Given this list of marker genes Hif1an, Maea, Sptlc2, Usp25, Tmem150c, Cgas, Rslcan18, Pcdh8, Naip6, Zfp446, Nid1, Dph6, Lhx6, Tcaim, 2510009E07Rik, Nipal1, Ythdc2, Chst11, Zrsr2, Creb3l1, Peak1, Rnpc3, Chn1, Fgf11, Cnksr2 (NCBI Gene Id 245684), Tns1, Tlx1, Nck2, Tenm2, Adtrp, Sytl5 (NCBI Gene Id 278231), Slc8a3, Rara, Tafa3, Hspg2, Kcnip3 (Kv channel interacting protein 3, calsenilin), Scn2a, Dhfr, Wars2, Mical2, Pdxk, Katnal1, Thada, Slc24a2, Slc37a1, Ccdc115, Sh3bp5, Fblim1, Zfp37, Nmrk2, Zmat4, Nfat5, AW554918, Tmem236, Tcp11l1, Wdr46, Ulk1, Ift57, Arhgap26, Sri, Nat8l, Man1c1, Map7d1, Fzd7, Xk, Cap2, Itgam, Slc6a17, Mrps25, Cask, Sh3rf3, Ppfia2 (protein tyrosine phosphatase, receptor type, f polypeptide (PTPRF), interacting protein (liprin), alpha 2), Tcte1, Camk1d, Tnfrsf11a, Plcb1, Terf2ip (telomeric repeat binding factor 2, interacting protein), Nr4a2, Rnf150, Treml2, Wipf3, Bicd1, Mylk4, Tor3a, Gas2l1, Hivep3, Mmp12, Foxl1, Dcx, Eogt, Aldh5a1, Scn3b, Cd19, Mcu, Prc1, Gna13, Gm4925, Gjc3, Cldn34c1, Micu2, Atg7, Mex3a, Gid8, Baalc (brain and acute leukemia, cytoplasmic), Slc48a1, Gabrb3, Dnaaf5, Bmpr2, Lrrc61, Fgf23, Tktl2, Steap2, Ado, 9330159F19Rik, Slc17a5, Pclo, Plxdc2, C1ql3, Zfp655, Zfp712, Ptchd1, Sh2d2a, Sox7, Frk, Rfx7, Adarb2, Tmem151b, Slc2a12, B4galt6, Sv2b, Flnb, Gcnt4, Unc93a, Pou2f2, Camta1, Hrh1, Rims2, Gm12886, Sipa1l1, Prkn, Tmem26, Ddr1, Vezt, Zkscan1, Dcaf17, Zdhhc21, Ogdh, Trp53i11, Astn1, Oacyl, Mapk8, Acsl4, Acot4, Pcdhgb4, Cntn2, Stxbp5, Dcaf1, Irag1, Stk10, S2bpcox16, Fig4, Znrf3, Mnt, Cd300ld, Shroom3, Enpp1, Sin3a, Cox16, Katnip, Kcna7, Apba1, Trmt2b, Zfp46, Depdc5, Ugt2b34, Ptpre, Gm5141, Alox8, Dtx3l, B3galt6, Ap1ar, Mtmr12, Rfx3, Enox2, Gas2l3, Amotl1, Ttll1, Hnrnpa0, Tigd5, Zfp663, Wiz, Sdr42e1, Rbm34, Cmklr1 (chemerin chemokine-like receptor 1), Kmt5a, Ttc39b, Elavl3, Tnrc6c, Neurod2, Tet2, Kif1a, Cd2ap, Mllt3 (myeloid/lymphoid or mixed-lineage leukemia; translocated to, 3), Micall1, Gnat1, Phf1, Pcdhga11, Mbnl3, Sbk3, Osr1, Psd2, Foxk1 (forkhead box K1), Evx2, Ssr1, Liph, St8sia1, Zfp276, Zfp936, Rhou, Abce1, Acot2, Rnf44, Vipr2, Syt15, Arih1, Pcdhga1, Nedd4l (NCBI Gene Id 83814), Opcml, Il18r1, Tsn, Apbb2, Ackr4, Efna5, Gnal, Cbln3, Zfp39, Tubb4a, Cacna2d4, Dio2, Asah2, Myo5a, Trim65, Asxl2, Calcoco1, Tafa1, Acvr2b (NCBI Gene Id 75114), Fbrs, Baz2b, Pappa2, L1cam, Ddx19b, Coq8a, Ms4a5, Tmco1, Bcor, Atp7a, 1700025G04Rik, Slc35a3, Lyrm9, Meak7, Grid1, Nab2, Pld5, Myorg, Zfp91, Ipcef1, Esf1, Med14, Dse, Eda2r (ectodysplasin A2 receptor), Ncam1, Chd7, Tmem18, Zfp68, Zfp764, Elovl6, Pappa, Maf, Lipe, Sim1, Vps33a, Bgn, Alpl, Trim60, Pik3r5, Itga9, Napepld, 2810021J22Rik, Srpx2, Zfp1008, St8sia3, Lclat1, Ms4a4c, Net1, Mlxip, Capn6, Unc13b, Gcnt1, Alkbh7, Map3k7, Chic1, Bst1 (NCBI Gene Id 269647), Glra2, Gfpt1, Cds2, Olig2, Ccdc85a, Sowahb, Eif4e, Muc13, Slc39a14, Elfn1, Cdc42ep4, Pakap, Tamalin, Elfn2, Ubxn2b, Rusf1, Atp11a, Podn, Actr10, Igf2r, Kcnmb1, Pign, Cplx3, Insyn2a, Rgs4 (regulator of G-protein signaling 4), Bltp3b, Pitpnc1, Cdc6, Smo, Havcr2, Zfp976, Fndc7, Tnfrsf13c, Nfya, Pgm5 (phosphoglucomutase 5), Ccdc125, Zyg11b, Mta3, Ly6g6c, Alg12, Acss1, Bard1, Nalf1, Gabrb2 (NCBI Gene Id 78533), Gm14391, Ifnlr1, Tmem132b, Cyfip1, Mrgpre, Yipf6, Iars1, 1700028K03Rik, Ppp1r16b, Kif3a, Kmt5b, Ubxn2a, Ajap1 (adherens junction associated protein 1), Gm38666, Thsd4, Prex2, Cacna1c, Mbtd1, Nufip2, Ncoa2, Zbtb7b, Vamp5, Klhl23 (kelch-like 23), Kras, Mettl27, Tnpo3, Arhgef17, Kank2, Uncx, Pfkfb2, Ddo, Vti1a, Ccdc3, Pcdhgc3, Kirrel3, Pcdhga6, Sox5 (NCBI Gene Id 319649), Ubtf, Sv2a, Cplx2, C5ar2, Thsd7a, Grik3, Coq5, Zfp799 (NCBI Gene Id 240064), Klf12, Fam186b, Prss42, Srgap3 (SLIT-ROBO Rho GTPase activating protein 3), Trim12c, Chrnb4, Desi2, Nqo2, D630023F18Rik, Plp1, Zfp691, Kif5a, Dlgap4, Cyb5b, Krt222, Ewsr1, Lgals12, Pcdhgb2, Mapkbp1, Fech, Orai2, Mmp28, Setd7, Prpf4, Cdh6, Arhgdib, Fam149b, Mfap3l, Pgrmc1, Nsun3, Cd84, Siah2, Angpt2, Zfp113, Acsm2, Pck2, Slc5a8, Nkx2-9, Prkcb, Wnt4, Ttc12, Zfp612, Cer1, Fgf12 (NCBI Gene Id 320320), Ehd4, Zfand5, Zfp329, Asb13, Cyp2j12, Itga3, Xylb (NCBI Gene Id 235676), Xpr1, Tacc1, Porcn, Prrc2b, Pde10a, Cyth3, Zfp575, Spock2, Sox1, Pate9, Tmem200a, Casp6, Kcnc1, Lnx2, Prdm12, Oprm1, Camk2a, Samd7, Sod2, Cyb5r3, Scn8a, Pfn1, Coro2b, Fam171a1, Gdpgp1, Galntl6, Grk3, Tgfbrap1, Zfp248, Sema5b, Dnai4 (NCBI Gene Id 242584), Foxn1, Trim30d (NCBI Gene Id 209387), Cradd, Shisal1, Ceacam18, Tmem47 (NCBI Gene Id 76833), Trim36, Muc4, Zfp747, Vsig10l, Cd28, Scaf11, Prxl2a, Carm1, Flt4, Ccdc71l, Gm14434, Gtf2h2, Zfhx3, Elavl4, Lrat, Acvr2a, Spin1, Cnih3, Pcdhga9, 1810065E05Rik, F830016B08Rik, Trpc7, Igf1r, Jmjd8, Ufm1, Rnf170, Spx, Fbxo31, Tyw3, Srsf12, Arid1b (AT-rich interaction domain 1B), E2f8, Fndc3a (NCBI Gene Id 76636), Rab11fip4, Anks1b, Mfsd6, Egr3, Zfp169, Pcdhgb8, Wdr59, Tmem141, Mocs1, Heatr6, Lrtm2, Rnasel (ribonuclease L (2', 5'-oligoisoadenylate synthetase-dependent)), Wipf2, Ubfd1, Mrpl19, Marchf1, Cend1, Zfp318, Itga11, Slco2a1, Aldh8a1, P2rx7, Epha7, Pnma2, Ank2, Ano3, Pcdha4b, Ppp1r9a (NCBI Gene Id 72734), Jmy (NCBI Gene Id 57748), Rhbdd1, Has2, Plekhg5 (pleckstrin homology domain containing, family G (with RhoGef domain) member 5), Mmab, Arhgef9, Pcdhga8, Cat, Fzd3, D430019H16Rik, Pcmtd1, Fubp1, Baiap2, Cp, Urb2, Septin11, Runx1, Iffo2, Rspo1, Nkain2, Col13a1, Ski, Clptm1 (cleft lip and palate associated transmembrane protein 1), Nmnat2, Aptx, Pura, St18, Ifi44, Prdm6, Snx12, Igf2, Cnga4, Cdk13, Prelid3a, Lsm1 (NCBI Gene Id 67207), Otx1, Rab11fip1, Cd160, Gpr68, Fcrl6, Gng2, Gadl1, Oxtr, Pcdh17, B4galnt2, Efnb1, Unc5a, Gria3, Acp3, Ggt5, Pcdhga7, Ric8b, Ermap, Adamts17, Nagpa, Krt6b, Ascl4, Cmc2, Tacr2, Fam174b, Cdk6, Slc6a1, Irgm2, Pcdh10, Klf6, Slmap, Kcng3, Onecut3, Rassf2, Pcdhgc4, Cyp2g1, Knstrn, Pilra, Pstpip2, Flrt1, Atg10, Ctdsp2, Mga, Prokr2, Cox10, Dgkg, Sys1, Ascl1, Insr, Optc (NCBI Gene Id 269120), Asap3, Gls, Igf2bp2, Nhsl1, Pacsin2, Ints10, Magee2, Tph1, Fam169b, Chmp1b2, Brwd3, Cfap74, Prss23, Irf2bp2, Dcakd, Pigh, Gng12, Xrcc3, Rgr, Tead1, Rit2, Trpc6, Rnft2, Pafah1b1, Cerk, Ttll7, Sema6a, Gask1a (NCBI Gene Id 245050), Tmem178b, Pcdhgb5, Acp1, Zfp516, Gm3604, Setd3, Mbtps2, Ccna2, Gm4724, Wscd1, Nab1, Nphp3, Lrrc32, Peg3, Kcnn3, Cacna2d2, Cntn3, Nat8f2, P2ry13, Hmga2, Elp4, Nbeal1, Dock5, Papss2, Cdh7, Lin7a, Pde1c, Supt7l, Runx3, Mymk, Ccbe1, Brix1 (NCBI Gene Id 97948), Dnah17, Akap13, Rmi1, Zmiz1, Tmod2, Dcun1d1, Mindy2, Slc35e2, Zfp827, Igfbp3, Nrxn1, Adgra1, Lcorl, Homer2, Rhobtb1, Chic2, Sowaha, Rab9, Barhl2, D630039A03Rik, Fat3, Kat6a, Bptf, Scd3, Zfp994, Mr1, Prdm8, Mlec, Zfp365, Emx2, Gata4, Cdh12, Psg29, Bdh1, Ptgfr, Frmd5, Col19a1, Ttc38, Mettl21e, Psd3, Mgat4a, Prr11, Adcy1, Trim56, Kcnk10, Phactr3, Nrip3, Ddi2 (DNA-damage inducible protein 2), Unc5d (NCBI Gene Id 320828), Fsd1l, Mon1b, Vangl2, Btbd8, Pou6f1, Dhx40, Prss59, Bnc2, B3gnt9, Kdm6b, Tvp23a, Slc31a2, Senp1, Aak1, Tgfa, Nufip1 (nuclear FMR1 interacting protein 1), Smyd3, Ptpn14, Dppa1, Klhl13, Zfp92, Sdf4, Pcdhga2 (NCBI Gene Id 93710), Rasa2, Slc10a2, Zfp810, Ggact (NCBI Gene Id 223267), Tirap, Slc22a15, Mdga1, Plxna2, Hpca, Pogk, Ift46 (intraflagellar transport 46), Nt5e, Ctse, Bend3, Slc6a6, Smarca2, Gucy2e, Bmp3, Golm2, Atrn, Nav1 (neuron navigator 1), Dlgap2, Garem2, Dmrta1 (doublesex and mab-3 related transcription factor like family A1), Doc2b, Zfp607b, Casp8, Ino80d, Zeb2, Foxa1, Polr3b, Lpp, Rab2b, Cnpy3, Cdc27, Pcdhga12, Iars2, Ube2q1, Tub, Lcp2, Cox15, Ilrun, Adamts14, Brinp1, Rab6b, Macroh2a2 (NCBI Gene Id 404634), Urod, Ncam2, Vtcn1, Rrm2, Pirt, Cxcl12, Htt, Rras2, Diaph2, Rora, Arpp21, Rabgef1, Nrp2, Fbxw28, Adhfe1, Peli2, Clec2l, Bach2, Synj2bp, Wrn, Ralgapa2, Gabbr1, Zfp641, Snurf, Htra4, Arhgap25, Snrpn, Gm6710, Mdm2, Greb1, Gm14137, Scn5a, Gm14308, Cstf3, Syn3, Prim2, Eif2b3, Cxcl15, Slc25a21, Deptor, Mapk6, Gnaz, D630045J12Rik, Dhh (desert hedgehog), Fermt1, Glis3, Tmtc3, Cdk5r1, Clvs1, Dlg4, Prps1l1, Trip12, Csrnp2, Zc3h12d, Adra1b, Fbxw5, Rpusd2, Onecut2, Srxn1, Avl9, Slc1a2, Riok3, Npr3, Pdcd4, Slc25a10, Pou3f4, Cd99l2, Napb, Sp9, Gabrg2, Hook3, Gabrq, Chst3, Tmem104, Mecp2, Brinp2, Klhl9, Tmt1a3, Cd274, Pcdhga4, Pcdhga5 (protocadherin gamma subfamily A, 5), Zfp696, Slc30a10, Hoxc13, F10, Meis2, Nfasc, Dusp7, Hycc2, Pgap1 (post-GPI attachment to proteins 1), Gm14151, Cnot7, Cd27, Kcnb1, Lrrn4cl, Ubap2l (NCBI Gene Id 97055), Srf, Slco3a1, 9030624G23Rik, Loxl4, Bdp1, BC030500, Deup1, Itsn1, Slc4a8 (NCBI Gene Id 59033), Zfp606, Ece1, Atp2b2, Pard3b, Rabl2, Septin6, Prr5l, Accs, Tbc1d30, Paics, Trpm3, Lbp, Pfkp, Metrnl, Kcnj1, Ugcg, Erg, Tent5a, Pdzrn3, Man2a2, Hoxb4, Epha4, Idua (iduronidase, alpha-L), P4ha3, Apela, Tbx15, Dkk1 (dickkopf WNT signaling pathway inhibitor 1), Galnt13, Ddx51, Ceacam1, Pcdhga3, Nrk, Sspn, Plppr3, Zfp266, Mrpl17, Actr1b, Tppp, D630003M21Rik, Sike1, Proser3, Smpd4, Neu1, Septin3, Srp9 (NCBI Gene Id 27058), Cd4, Stat6, Tnr, Zfp239, Rpp25, Lyz3, Trim67, Nos1, Atp2b3, Garre1, Celf4, Rab3c, Slc25a12, Stxbp4, H2-M2, Pecam1, Zfp74, Cacna1e, Tgfb2, Plac9, Ppp1r1c, Slc7a1, Endov, Shisa6, Slc8a1, Rimkla (NCBI Gene Id 194237), Runx1t1, Cgnl1, Rgs9bp, Btbd3, Slamf1, Fbxo30, Rgs17, Chst2, Tfap2b, Tpgs2, Pgbd1, Edaradd, Kcna2, Stard8, Tacr1, Pof1b, Ptprb, B4galt5 (UDP-Gal:betaGlcNAc beta 1,4-galactosyltransferase, polypeptide 5), Prr18, Glyr1, Pcdhgc5, Eef2k, Atm, Stambp, Mcidas, Trub2, Nkain3, Iqgap2, Kcnv2, Csf2ra, Hexim2, Chrdl1, Maml3, Art1, Map3k20, Borcs8, Slc16a5, Slc22a8, Msrb3, Rab7 (RAB7, member RAS oncogene family), Bcl2, Lims1, Plpbp, Ostm1 (NCBI Gene Id 74109), Gm2026, Creg2, Prlr, Prkcg, Oxsm, Methig1, Cd33, Slc35d2, Dcdc2a, Lnpk, Cdh20, Acox3, Acot3, Sox12, Pdik1l, Fmn2, Uvssa, Zfp488, Dixdc1, Vps37a, Elovl5, Cfap97, Myrip, Cflar, Nmrk1, Vangl1, Ebf3, Gpr45, Creg1, Dnlz, Nrbp2, Ehd3, Acmsd, Zfand2a, Slc38a6 (NCBI Gene Id 640113), Prkci, Igsf6, Ctsc, Mblac2, Meltf, Rrm2b, Hdac8 (NCBI Gene Id 70315), Cd47, Ppih, Cmah, Gpr173, Ttc14, Ttc4, Pcdhgb7, Ptgdr, Nlgn3, Chrnd, Extl3, 4921509C19Rik, Lhx5, Nxpe3, Slc7a8, Megf8, Zfp831, Rasal2, Adgrf5, Lratd1, Cyp4a31, Dnase1l3, Ago3, Csmd1, Triobp, Mobp, Gfod1, Esr2, Il1rap, Dmd, Mapk11, Sema5a, Vapb, Rnft1, Ceacam2, Gcm2, Evi2b, Nkap, Cpm (NCBI Gene Id 70574), Dlg1, Mrap, Usp45, Fgfrl1, Egfl6, Slc4a4, Sh3bgrl2, Nudt13, H2bc6, Prkaa1 (protein kinase, AMP-activated, alpha 1 catalytic subunit), Serinc3, AI429214, Rgs5, Tc2n, Efcab14, Mafb, Six6, Clec4g, Jarid2, Dhdh, Fam107a, Cstad, Cygb, Sh2b3, Zfp449, Cdc37l1, Kcnq2, Vwa5b2, Sp100, Vegfb, Glra1, Pcdhga10, Zfp704, Ptch2, Ildr2, Vsnl1, Sparc (secreted acidic cysteine rich glycoprotein), Enpp6, Trem1, Atxn1, Dapp1, Adam12, Slc25a31, Unc5c, Gabra2, Ap3s2, Mtus2, Rreb1, Bcl2l11, Ankrd34a (NCBI Gene Id 99882), Lhfpl3, Kcnj15, Gbp7, Ngfr, Prox1, Stk32a, Abcc9, Rorb, Stxbp5l, Sarm1, Trpc5, Fbxl17, Bean1, Ssbp4, Rfk, Pou4f2, Snai2, Gab2, Gatc, Cipc, Rp1, 3425401B19Rik, Iglon5, Pou3f2, Dctd, Zscan29, Gulp1 (GULP, engulfment adaptor PTB domain containing 1), Glce, Snap23, Itga4, Tmem52b, Lcmt2, Ralb, Nwd1, Il22ra1, B3galt1 (NCBI Gene Id 70755), Draxin, Pcdhgb6, Pank1, Svip, Pcdhgb1, Pitpnb, Reps2, Prkca, Gm14325, Tti1 (TELO2 interacting protein 1), Rad18, here is a description of the gene set: species: Mus musculus from publication Chen Y, Wang X (PMID 31504780) Genes predicted to be targets of miRBase v22 microRNA mmu_miR_466k in miRDB v6.0 with MirTarget v4 prediction scores > 80 (high confidence targets). Mouse Gene Set: MIR_466K